Given this list of marker genes POMP (proteasome maturation protein), CARD10, FCGR2C, AIRE, RASGRP1, THRB, DOCK11, TSHR, NFKB2, here is a description of the gene set: Anti-thyroglobulin antibody positivity Human Gene Set: HP_ANTI_THYROGLOBULIN_ANTIBODY_POSITIVITY The presence of autoantibodies (immunoglobulins) in the serum that react to thyroglobulin. studied in species Homo sapiens